The following is a description of a gene set: from publication Yevshin I, Sharipov R, Kolmykov S, Kondrakhin Y, Kolpakov F (PMID 30445619) Mouse Gene Set: SAP18_TARGET_GENES Genes containing one or more binding sites for (Sap18) in their promoter regions (TSS -1000,+100 bp) as identified by GTRD version 20.06 ChIP-seq harmonization. studied in species Mus musculus, and this is the list of marker genes: Lcmt2, Chpt1, Vil1, Nudt6, BC031181, Churc1, Iws1, Hbp1, Ddias, Rbm42, mt-Ty, Gm11983, Mir6925, Sdk2, Gm10222, Ddx19a, Bccip, Rad50 (NCBI Gene Id 19360), Izumo2, Guk1, Faap24, Alkbh3, Nrbp1, Cplane1, Ahcyl1, Srd5a1, Arhgef2, Mdh1b, Ighv1-67, Stk3, Spty2d1, Ogfod3, Tmem203, Zfpl1, BC005624, Nsa2, Phf7 (NCBI Gene Id 71838), Syngr4, Zeb1, Lrrc28, Git1, Endov (NCBI Gene Id 338371), Bap1, Rpl26, Krit1, Nsmce3, Zdhhc3, Mir423, Zfp369, Prpf6, Ap2m1, Gm9104, Snapc1, Nup214, Prep, Pdzd9, Cul4a, Larp4, Ccnf, Nudt1, Ssna1, Pcbp1 (NCBI Gene Id 23983), Sf3b1, Trappc2b, Arb2a, Med27, mt-Ts2, Cfap68, Zfp57, Map3k13, Gstcd, Hp1bp3, A330023F24Rik, Ap1g1, Ppp4r3b, Gm5067, Atg9b, Afg2a, Ublcp1, Smap1, Cpped1, Hint3 (NCBI Gene Id 66847), Lmbr1, Magoh, Dcaf11, A730081D07Rik, Txnl4b, Mthfd1, 6430573P05Rik, C87436, Htatsf1, Ppp1r12b, Gmppb, Rfc4, Pphln1, Carnmt1, Nfx1, Unc45bos, Tfcp2l1, Fam167a, Mrpl55, Hat1, Slc35b1, Mtif2, Plaa, Rad17, Zfp729a, Noc4l, Gm15387, Cul5, Rrp1b, Kptn, Gm25887, Dennd1a, Pot1a, Xab2, Snrpa, Yipf6, Exoc4, Acox3, Sdhaf3, Dusp1, Zfp74 (NCBI Gene Id 72723), Ncln, Med28, Vamp4, Sppl2a, Commd7, Nelfe, Map3k7, Tsnax, Cep164, 4931415C17Rik, Tti1, Cog5, Pi4kb, Ank1, Fhod3, Mir7075, mt-Tp, Rpl37a, Pdcl, Apc, Ak6, Smg7, Mak, Drap1, Ranbp1, Coa5, Drosha, Rad51ap2, Tdrkh (NCBI Gene Id 72634), Prpf31, Zfp580, Slc25a16, Spin1, Nipal3, Synrg, Rock2, Nsrp1, Kat5, Zfp367, Atrip, Ppp1r14b, Gtf2h1, Fahd2a, 6330549D23Rik, Prr11, A230103J11Rik, Cyb561a3, Pds5a, Rgs3, Tpr, Slc36a1 (NCBI Gene Id 76010), Nat10, Chct1, Nav2, Gtf2h3, Kmo, Klhl7, Mrps17, Crk, Cnot1, Inhca, Dimt1, Tgfbrap1, Slc1a1, Bod1, Dhx30, Rpl24, Skap2, Slc39a14, Zbtb6, Trap1, Anks3, Aasdh, Acad12, Pigx (NCBI Gene Id 72084), Prss36, Recql5, Myl4, Tbc1d14, Btg3, Mia3, E2f7, Dyrk3, Aco2, Akap1, Bbc3, Dxo, Pnrc2, Bloc1s5, Dync1i2, Stk16, Pggt1b, Phlda3, Kif7, Snapc4, Itpr3, Bloc1s4, Orc5, Ccdc17, Scnn1g, Pfas, Vps72, Cyb5a, Cert1, Klhdc4, Nphp1, Gm22489, Ctnnbl1, Ndufa10, mt-Nd1, Taf9, Gm30097, Thoc3, Faf1, Spcs1, Wapl, Cers2, Uvssa, Srprb, Esco1, 1600020E01Rik, Tfpt, Syne3, mt-Nd5, Wdr74, Tbl3, Tmem237, Tsn, 3110031N09Rik (RIKEN cDNA 3110031N09 gene), Ptpre, Bcl2l2, Vps13b, Fgd4, Dnase1, Gm7291, Klhdc9, Dnajb11, Gm15910, Kbtbd7, Strn3, Abcb10, Zfp982, Rbm18, Tubgcp6, Ngly1, Rbm17, Gnai1, Pigk, Hoxaas3, Ddx52, Gne, 4930568D16Rik, Traf4, Fbxw2, Cdkn1a, Adal, Gm6654, Mapk1ip1 (mitogen-activated protein kinase 1 interacting protein 1), Rpph1, Erlin2, Dhx40, Purb (purine rich element binding protein B), 4930573C15Rik, Nop9, Mei4, Cct6a, Wdr53, Ift52 (NCBI Gene Id 99173), Taco1, Tmem183a, Nudt19, Nbr1, Egf, AI597479, Gm14455, Ino80d, B230354K17Rik, Jtb, Plb1, Lime1, Mdm4 (NCBI Gene Id 98570), Use1, Slc25a53, Ube2h, Ddx19b, 4930513N10Rik, Dhrs13, Anapc2, Fntb, Elp5, Xrcc1, 4930547M16Rik, Snora73a, Surf6, Gm13067, Rprd1b, Xpnpep3, Rps19, Rpl18, Mcm8, Gm13377, Stradb, Kcnd3, Cbx5, Sra1, Aamdc, C630050I24Rik, Pdk2, Dlg5, Bet1, Ranbp6, Senp3, Nup42, Gm3242, Lsr, Abce1, AA914427, Mrpl20 (NCBI Gene Id 73950), Gm21978, D030068K23Rik, Dus1l, Nras, Snora74a, Eef1a1, Mapkapk5, Atxn1l, Sft2d1, Slc35f5, Lrrc14, Ttc9c, Inpp5d, Srrm2, Thsd7a, Trmt61b, Socs4, Caap1, Prss44 (NCBI Gene Id 73336), Rce1, Ulk2, Uqcc4, Ntan1, Tmem143, Mecr, Gtf3c2, Gm26504 (NCBI Gene Id 64243), Ndor1, Cox7a2l, Mgat1, Mfsd14b, Gm13135, Sphkap, Tmem39a, Dhx32, Krr1, Gm19345, Tfip11, Ndel1, Dhx38, Tbp, Chadl (NCBI Gene Id 360225), Acaa1b, Anapc15, Smndc1, Lrr1, Spata31e2, 4632411P08Rik, Brk1, Scpep1os, Satb2, Abl2, Ctdnep1, Noxo1, Lias, Gm13981, Ube2j1, Zfp593, Rabl3, Mrpl4, Zcrb1, Foxred1, Unc45b, Glb1l, Ctc1, Sh3d19, Srsf11, Rbpms, Dhx35, Glt8d1, Pdcd7, Sik1, Wdhd1, Tomm6, Morf4l1, Atp9b, Abcf2, Zdhhc4, Epcam, Pccb, Gm26265, Adam21, Zfp248, Ramacl, Hoxa7, Ptpn11, Vps18, Tmem242, Samd9l, St3gal2, Eif2b1, Prkca, Mrpl13, Hps4, Gar1, Rrm2b, H3c6, Casp6, Gm14107, Ptpn14, 0610040B10Rik, 1700011L22Rik, Lrrc59, Aurka (NCBI Gene Id 99385), 9030407P20Rik, Pabir1, Pip4p2, Trmt10a, mt-Td, Ppp2r5a, Zfand2a, Dus2 (dihydrouridine synthase 2), Rbm22, Trmt12, Odf2l, St8sia5, Gigyf2, Marchf6, Dpysl4 (dihydropyrimidinase-like 4), Sart3, Dctn5, Lgr4, Eef1akmt3, E4f1, Gm10182, Bptf, Fbxl21, Erp44, Wiz, Srrd, Elovl5, Naf1, Syde2, Phf20l1, 4930449E01Rik (NCBI Gene Id 74864), Zfp386, Polr1has, Rida, Actl6a, Vamp2, Kmt2b, Fam162a, Isoc2b, Gm15526, Polr1f, Aar2, Nhlrc3, Dnajb12, H2ac7 (H2A clustered histone 7), 2700099C18Rik, Timm44, Cstf1, Rnf166, Rhot1, Sfmbt2, Gtf2h5, Rnps1, Ccnt2, Ap2b1, Capza2, Pop1, St18, Fbxo45, Ctu2, Gpr137c, Rrm1, Eif4a1, Gm21411, Zfp457, Stk33 (serine/threonine kinase 33), Mir6397, Clpb, Psmd11, Snf8, Yeats4, Psmd5, Dcp1b, Sgf29, Ppil4, Pop4, Cep89, Vps54, Gm8379, Spata7, Gm13162, Ift172, Blm, Snrpc, 2610005L07Rik, Tmem147os, Fcgbpl1, Nit1, Zdhhc18, Pex1, Mrps5, H3f3b, Nelfa, Hace1, Slc22a14 (solute carrier family 22 (organic cation transporter), member 14), Rfc1, Terb1, Ubn2, Ubac1, Tpd52l2, Txndc15, Fbxl20, Ripor2, Mfsd13b, 6820431F20Rik, Emg1, Med6, Asb3, Ubqln1, Snora73b, Zfp998, Zc3h13, Gle1, Cox18 (NCBI Gene Id 231430), Thumpd1, Acot1, Tysnd1, Trub1, Zfp738, 1110059G10Rik, Tial1, Pwp1, Mir3569, A230056P14Rik (NCBI Gene Id 320845), mt-Co2, Pex12, Adar, Cnnm2, Zgrf1, Ncbp2, 5830454E08Rik (RIKEN cDNA 5830454E08 gene), Ap5s1, Twf1, Mir28a, Fbxw9, 1810019D21Rik, Celf2, Safb, Bmpr2, Rbm48, Rft1, Rnf4, Zcchc8, Mtln, Zc3h3, Terf2, Smim17, Mettl25b, Tnfsf13os, Hormad2, Ncbp2as2, 3110082I17Rik, Emc3, Letm1, Bmpr1a, Mrpl12, Snora15, Cmtr1, Atpaf2, Esyt2 (NCBI Gene Id 74047), Mettl25, Kif2c, Ppwd1, Ppp1cb, Rab4b, Ccnyl1, Slc6a21, Cpeb2, Cbll1, Septin2, Znrd2, Gm11936, Zfp365, Brd10, Ccdc127, Mrrf, Mmp17, Gm13228, Gm22417 (NCBI Gene Id 115486758), Atp1b3, mt-Tn, Wdr4, Zfyve19, Zfp64, Zfp493, D330041H03Rik, AI837181, Lrrc40, Ankrd22, Wdr45b, mt-Tc, Cab39l, Kcnh1, Tsg101, Airim (AFG2 interacting ribosome maturation factor), Sec11c, Trp53inp1 (transformation related protein 53 inducible nuclear protein 1), Dph3, Ppp4r1, Rps27l, Tug1, Tbccd1 (NCBI Gene Id 70573), Coq7, Hacd2, Snhg17, Nudcd2, Gm29609, Taf11, Spdye4b, Ftsj1, Kat2a, Afg3l1, Myh9, Bud23, 2310033P09Rik, Xpo4, Zfyve27, Megf10, Cenpe, Ldah, mt-Cytb, Larp7, Ndufb6, Gm1401, Edf1, Pinx1, U2af1, Tbrg4, Esrp2 (NCBI Gene Id 77411), Mdn1, Clptm1l, Nedd8, Tbck, Mir7070, Trmt61a, Ei24, Zfp750, Ss18l2, Gm19353, Isy1, Sptbn4 (spectrin beta, non-erythrocytic 4), Ndufb5, Cenpw, Ccdc28a, Pnn, Tmem147, Cenpl, Trnt1, Trmt44, Spaca9, Pfdn2, Ttc4, Snhg3, Cspp1, Gm16570, Nop58, Cdc23, Oxnad1, Fibcd1, Fbxo36, Zcchc3, Msh2, Gm12481, Xaf1, Smu1, Srsf10, Zranb1, Emc7, Prrc2a, Pet100, Vps11, Bcl3, Supv3l1, Dhrs1, Gm16998, Uros, Nolc1, Ttc39d, Wdr31, Rprm, Serac1, Snx18, Cope, Senp2, Elavl1, mt-Rnr2, Hdlbp, Ccnh, C1d, Cdadc1, Ap1ar, Cad, Commd3, Tppp, Smarcc1, mt-Ta, mt-Th, Dars2, Snhg15 (small nucleolar RNA host gene 15), Mtbp, Trak2, Lonp1, Hps5, Arfrp1, Syt2, Rtf2, Mir6236, Rpp14, Fhl4, Sptlc1, Anapc10, Lmf2, Wdr90, Sfi1, Nipa2, Ccl25, Gin1, Polr3f, Mrpl2, Invs, Sgcd, Ppp2r2d, Pelp1, Atn1, Arhgef7, Gm15483, Cct4, Idh3b, Abitram, Ess2, Cipc, Dnajc25, Platr7, Zc3h18, Zfp65, Kctd20, Usp14, Dcaf1, Mzt2, Plekha2, Slc47a2, E030030I06Rik, Ass1, Zfp653, Srgap2, Lrrc57, Gmpr2, Erg28, 9530068E07Rik, Ankra2, Ndufaf1, Zbtb37, Tmem87b, Hmcn2, Snx8, Sec22b, Chmp4b, Cpeb3, Cyp4f16, Ahcyl2, Med20, Zbtb45, Ccng1, Zkscan16, Grip1, Tmbim4, Gm12002, Ccnk, Ginm1, Osbpl8, Gm37450, Brca2, Fastkd2, Tubb2b, Nubpl, Polb, Rev1, Ints12, Gm26345, 4930506C21Rik, Rnpepl1, Bcap29, Skic2, Abca5, Shc1, Gas5, Aptx, Cdc27 (cell division cycle 27), 1700028K03Rik, Coq9, Dnm3, Nup58, Med9, Setd4, Btbd9, Smg8, 4930532G15Rik, Slc38a6, Rnf44, Atad3a, Rbm15, Drd1, Man1b1, Rps6kb2, Magohb, Rab8b, Ckmt1, Ncaph2, Eef2, Hmmr, Epn1, Gfm2, Ighv12-2, Paip1, Eftud2, Topbp1, Rpl22, Nufip1, Pnpla8, Cdo1, Rps19-ps5 (ribosomal protein S19, pseudogene 5), Dbr1, Exosc9, Ltv1, Npnt, Kxd1, Braf, Pi4k2a, Gpn3, 1700030C10Rik (RIKEN cDNA 1700030C10 gene), Ormdl3, Smarcad1, Nrsn1, Nlgn2, Cyb5r1, Tardbp, Zswim2, Phf5a, Ttc14, 5730480H06Rik, Cdiptos, Coa4, Gm43578, Aen, Mettl1, Ficd, Spryd3 (NCBI Gene Id 223918), Gtpbp10, Rbm8a, Emc4, Vcpkmt, Snora9, Isg20l2, Nek1, Gosr2, Cct6b, Dzank1, Gtpbp6, Senp5, Papola, Pak1ip1 (PAK1 interacting protein 1), Arhgap11a, Pgap2, Copa, Mix23, Igsf9, Rpl23, 4930566F21Rik, A230072C01Rik (NCBI Gene Id 320742), Crebrf, Zbtb17, Ddx10, Ankrd17, Trim37, Zfp661, Ttll5, Romo1, Sphk2, Cnot7, Dnttip2, Zzef1, Rps12, Pdia5, Gm10631, Tfpi, Saraf, Safb2, Stx18, Ap4b1, Uxt, Ift88, Phtf1, Ddx49, 1110038F14Rik, Gan, Sugt1, C530005A16Rik, Atg16l1, Sp1, Haus2, Gm16001, Tubgcp3, Cactin, Iqch, Scaf11, Dnajc30, Ice2, D2hgdh, Fbxl18 (NCBI Gene Id 231863), Srd5a3 (steroid 5 alpha-reductase 3), 1700095J07Rik, Wdr70, Uqcrfs1, Prim1 (DNA primase, p49 subunit), Iscu, Gm15564, Yy2, Pou2f3, 2610507I01Rik, Gm13025, Pdlim4, Cpsf1, 1810044D09Rik, Psrc1, Dclre1b, Pde7a, Sap30bp, Mrpl49, Vamp3 (NCBI Gene Id 320838), Snrpg, Rps29, Cenpk, Gpalpp1, Acad9, Rpl9, Dnajc17, Prkrip1, Rmdn3, Rtn4, Palb2, Ccl9, Morc2a, Terf1, Gm26800, Efcab14, Ciapin1, Itpripl2 (inositol 1,4,5-triphosphate receptor interacting protein-like 2), Mfsd4b4, Trmt13, Gm22357, Dus4l, Clcn3, Scfd2, Nfatc2, Arf2, Cdipt, Mrpl15, Tyw1, Fau, Gm20517, Pogk, Col26a1, Prodh, 5031425E22Rik, Slc20a1, Rnmt, Rbak, Pik3c3, Mbtps2, Nup85, Gabbr1, Ndufs7, Arih1, Rcbtb1, Czib, Slc35e1, St13, Hc, B230322F03Rik, Ube4a, Asb8 (NCBI Gene Id 78541), Prss38, Recql4, Atp5pb, Map1lc3a, Guf1, Cyb5d2, Ctcf (CCCTC-binding factor), Ankrd24, Gps2, Arnt, Exosc7, Ak8, Srsf6, Mettl14, Etv3, Rab10os (RAB10, member RAS oncogene family, opposite strand), Kctd5, Trmt2a, Zfp523, Dcaf13, Sike1, Gm10171, Dync2i1, Ccdc86, Gm14040, Kdm5a, C130060C02Rik, Prr3 (proline-rich polypeptide 3), Ubap2, Dpy30, Gatc, Odr4, Srpra, Abt1, Piga, Atp6v0a2, Fbxo34, Rrp1, Gm6445, Naa40, Rpp38, 1700096K18Rik, Gm15510, Dennd4b, Gm10010, Rccd1 (RCC1 domain containing 1), Frs3, Mul1, Sass6, Ssu72, Myl6, Trip12, Ankib1, Marf1, Cwf19l1, Snora21, Gnl1, Gk5, Zfp664, Snapc5, Wdr35, Eprs1, Psmb2, Cep78, Cwc25, Arfgap3, Mfn2, 4930518I15Rik, Fbxw7, Ganc, Polr1h, Mbip, Haus5, Phb2, Rnf215, Dhx36, Rab12, Mttp, Rnf19b, Tmco1, Ccdc124, Gatad2a, Eng, Eldr, Slc27a2, Golga4, Ndufc2, Zfp61, Hemk1, Gmeb2, Rapgef2, Ppp1r12c, Ppp4c, mt-Tv (NCBI Gene Id 17745), Taok1, Secisbp2, Wdr59, Gm27211 (predicted gene 27211), Gm9958, Sdha, Cdc42se2, Trmt6, G730003C15Rik, Gm5973, Usp8 (NCBI Gene Id 99418), Nol10 (nucleolar protein 10), Gm8357, Polr2m, Mrpl41, Pals2, Slc1a4, Cops3, Malsu1, Ccdc103, Kif15, Klhl8, Gm10829, Esf1 (ESF1 nucleolar pre-rRNA processing protein homolog), Nup153, Gid4 (NCBI Gene Id 66771), mt-Tl2, Mrm2, Glod4, Parp2, Haus6, Or2bd2, Prss42, Mdm2, 6030443J06Rik, Dhx8, Ppp4r3a, Thoc1, Mllt10, Cbr4, Adgrl2, Nsun2, Adpgk, Zfp451, Txndc17, Cops8, B230317F23Rik, Enah, Zgpat, Nup155, Zng1, Mmut, Spag9, Rnf139, Stxbp4, Stk36, Syna, Ubr4, Cdca5, Sbds, Rps3, Chmp4c, Ipo11, Hnrnpu, Dtx3l, Nubp1, Setd3, Rnf141, Emc6, Rap2a, Med9os, Vps37a, Coq2, Rcc1, Naa25, H4c16, Rpusd2, Brca1, Xpo6, Rarg, Wfdc3, Gm10827, Zfp759, Irgq, Ndufv1, Trp53cor1, Lsm2, Clba1, 1700001J03Rik, Zfp638, Tmem43, Dhx33, Pnpla7, Mosmo, Stk19, Aagab, Cnot4, Fdxr, Clasrp, Ssbp1, Srcap, Comtd1, Sec31b, Gnpnat1, Gm12522, Sec62, Ddx27, Cdca8, Cdk20, Duxf3, Arhgap42, Cnpy3, Cry1, Tmem106a (NCBI Gene Id 74806), Tra2a, C030034I22Rik, Trir, Duxf1, Nbea, Fdxacb1, Gm11954, Usp20, Proser1, Mrm3, 1110046J04Rik, Ccdc106, AU040972, Unc50, Nipsnap2, Zfp36l1-ps, Rnf214, Pafah1b3, Gm26881, Tmem138, Zfp622, Akap7, Cmss1, Apmap, Tapt1, Senp7, Sox30, Dpcd, Snord15a, Ankle2, Skic8, B230206L02Rik, Smim30, Ift46, Txnl1, Brms1, Ska2, Pxylp1, Bdp1, Ranbp2, Pom121, Gtf2e1, Cetn4, Ckap2, Utp15, Gm15912, Nup133, Napepld, Gm17435, Pigg, Smpd4 (sphingomyelin phosphodiesterase 4), Trappc10, Tmem131l, Dffb, Wdr77, Pcmtd1, Gm10501, Elp1, Cep72, Fam135a, Pde4d, Secisbp2l, F2rl2, Ppig, Med23, Ccdc92, Capzb, A730061H03Rik, Ndufaf5, 2810408I11Rik, Rnf113a2, Ube2i, Tent5b, Hexd, Polr2k, Garem2, Mthfsd, Cdk5r2, Pskh1, Acat2, Gm21847, Gpam, Ddx51, Dhdds, Aimp1, Map3k10, Fancd2, Pcbp3, 2310008N11Rik, Pvt1, Pcsk7, Gm26740, Hps1, Pgm2l1, Oasl1, Tmem270, Txndc16, Col16a1, 4933427D14Rik, Cep19, Ak4, Pcid2, Mettl4, Nr4a2, Srsf7 (serine and arginine-rich splicing factor 7), Rlf, Triap1, Rnaseh1, Gm13034, Trmt5, Kctd18, Ankrd65, Atg5, Zfp566, mt-Tl1, Ube2v2, Blmh, Bysl, Dnttip1, Ccdc59, Sde2, Otud6b, Atg7, Poll, Gm26224, Cep104, Caml, Prdm9, Zfp87, Gpr89, Arf6 (NCBI Gene Id 11845), Psme3, Ogfod2, Zfp850, Pigo, Dglucy, Zfand5, Gm12121